The following is a description of a gene set: Gene sets differentially expressed in mouse cells, characterized by the tumor microenvironment between melatonin-treated and control samples in a xenograft model of triple-negative breast cancer using Balb/c athymic nude mice. from publication Jardim-Perassi BV, Alexandre PA, Sonehara NM, de Paula-Junior R, Reis Júnior O, Fukumasu H, Chammas R, Coutinho LL, Zuccari DAPC (PMID 30700756) Mouse Gene Set: JARDIM_PERASSI_TRIPLE_NEGATIVE_BREAST_CANCER_MOUSE_XENOGRAFT_MELATONIN_DN species: Mus musculus Balb/c athymic nude mice are unable to produce T-cells and are, therefore, immunodeficient. They are characterized by abnormal hair growth and defective development of the thymic epithelium. Insufficient information was provided in the publication regarding which specific Balb/c athymic nude mouse strain was used to generate the data., and this is the list of marker genes: F2rl1 (F2R like trypsin receptor 1), Plekhg3, Gpc4, Mical2, Col4a5, Eya2, Fzd1, Tenm2, Ppp1r3b, Penk, Prkca, Nectin3, Tarbp1, Dsg2